The following is a description of a gene set: part of: TCF dependent signaling in response to WNT Reactome Pathway: Disassembly of the destruction complex and recruitment of AXIN to the membrane species: Homo sapiens Upon stimulation with WNT ligand, AXIN and GSK3beta are recruited to the plasma membrane through interaction with DVL. Polymerization of membrane-associated DVL and GSK3beta- and CSNK1-mediated phosphorylation of LRP5/6 establish a feed-forward mechanism for enhanced membrane recruitment of AXIN upon WNT signaling. In Xenopus oocytes, but not necessarily all sytems, AXIN is present in limiting concentrations and is considered rate limiting for the assembly of the destruction complex. The recruitment of AXIN away from the destruction complex upon WNT stimulation effectively destabilizes the destruction complex and contributes to the accumulation of free beta-catenin. AXIN association with the destruction complex is also regulated by phosphorylation. In the active destruction complex, AXIN is phosphorylated by GSK3beta; dephosphorylation by protein phosphatase 1 (PP1) or protein phosphatase 2A (PP2A) destabilizes the interaction of AXIN with the other components of the destruction complex and promotes its disassembly. Free AXIN is also subject to degradation by the 26S proteasome in a manner that depends on the poly-ADP-ribosylating enzymes tankyrase 1 and 2. <br>, and this is the list of marker genes: PPP2CB, WNT8A, PPP2R1A (NCBI Gene Id 5518), PPP2R5A, AMER1, FZD2, LRP5, CSNK1G2, CTNNB1, WNT1, FZD5, LRP6, WNT8B, DVL1, PPP2R5D, APC, WNT3A, CAV1, CSNK1A1, FRAT2, AXIN1, FRAT1, DVL2, PPP2CA, PPP2R5B, PPP2R5E, PPP2R1B, DVL3, FZD1, PPP2R5C, GSK3B